The following is a description of a gene set: Negative regulation of FGFR4 signaling species: Mus musculus Mouse Gene Set: REACTOME_NEGATIVE_REGULATION_OF_FGFR4_SIGNALING, and this is the list of marker genes: Mapk1, Fgf15, Fgfr4, Ptpn11, Mapk3, Fgf1, Ubc, Mknk1, Ppp2ca, Fgf17, Fgf4 (fibroblast growth factor 4), Src, Ubb, Grb2, Klb, Fgf9, Fgf8, Uba52rt, Fgf16, Fgf23, Fgf20, Cbl, Fgf6, Frs2, Spry2, Braf (NCBI Gene Id 97330), Fgf18, Rps27a, Ppp2cb, Ppp2r1a, Uba52, Fgf2